Given this list of marker genes MIR29C, CDC42, MIRLET7E, MIR29B2, TP53, MIRLET7A1, MIRLET7F2, MIRLET7C, MIRLET7A2, E2F3, MIR34C, MIR148A, MIRLET7F1 (microRNA let-7f-1), MIR148B, MIR101-2, MIR29B1, MIRLET7B, MIR34B, CDK6, MIRLET7G, PIK3R1, MIR34A, MIR101-1, MYC, MIRLET7D, here is a description of the gene set: species: Homo sapiens Metastatic brain tumor Human Gene Set: WP_METASTATIC_BRAIN_TUMOR